The following is a description of a gene set: Acyl chain remodelling of PC Human Gene Set: REACTOME_ACYL_CHAIN_REMODELLING_OF_PC studied in species Homo sapiens, and this is the list of marker genes: LPCAT4, PLA2G10, LPCAT1, PLA2G2E, TMEM86B, PLA2G2A, PLA2G4D, LPCAT2, PLA2G2D, PLA2G1B (phospholipase A2 group IB), PLAAT3, PLA2G12A, PLA2G4C, PLA2G4F, LPCAT3, PLB1, PLA2G3 (phospholipase A2 group III), PNPLA8, PLA2G6 (phospholipase A2 group VI), PLA2G2F, PLA2R1, PLA2G4B, PLA2G4E, MBOAT2 (membrane bound O-acyltransferase domain containing 2), PLA2G4A, PLA2G5, PLBD1 (phospholipase B domain containing 1)